The following is a description of a gene set: species: Homo sapiens Human Gene Set: WP_TRANSCRIPTIONAL_ACTIVATION_BY_NRF2_IN_RESPONSE_TO_PHYTOCHEMICALS Transcriptional activation by NRF2 in response to phytochemicals, and this is the list of marker genes: CEBPB, NFE2L2, KEAP1, MAF, AIMP2, GCLC, HMOX1, PIK3CA, SLC7A11, GSTA2, NQO1, GCLM, PRKCA, EPHB2, MAPK8